Given this list of marker genes CRTC2, PRXL2B, EHMT2, KANSL3 (NCBI Gene Id 55683), IRF9 (interferon regulatory factor 9), GGACT, ARPC3, MYO1G, PLCD1, FAS, NUP210, MSRB1, TMEM107, TRANK1, ABHD14B, MARF1, SPSB2, DNTTIP1, ETFRF1, ZNRF2, CLEC2B, UBAC2, SEL1L3, MAU2 (NCBI Gene Id 23383), ZNF37BP (NCBI Gene Id 7588), EBP, PRKD2, MYBL1, YAF2, TXNDC12, LETMD1, SELENOW, MGAT1, ABHD3, TMED10, DFFB, PI4KB, NAA60, LRRC37A4P, CRYZL1, PHTF1, SPG7, GTF3A, PASK, MED20, ZNF512B, RCN2 (NCBI Gene Id 5955), TTC28-AS1, RNF34, KAT7, THAP8, PCBP1, ZNF780A, CASP8, AKT2, OSGEPL1, CAPNS1, LPGAT1, C2orf74-AS1, IKBKB, PINK1, DERA, TBCC, CARD19, AK3, EFCAB14, MOV10, SLTM, GTF3C2, GLE1, PPP2R5D, TCFL5, TRAM1, PCGF3, VPS41, UVSSA, APOLD1, ABHD15, AHI1-DT, PCBP1-AS1, ZDHHC13, TPM4, SH3BGRL3, SH3BP5-AS1, ERG28 (ergosterol biosynthesis 28 homolog), DIAPH1, RAB2B, RALA, MARCHF2 (NCBI Gene Id 51257), SPIDR, C8orf44, PLOD3, R3HCC1L, DND1, ZNF337, KLHL22, RASAL3, KPNA5 (karyopherin subunit alpha 5), MED22, LCP2, CDK5RAP2, SMC2, SPIN4, HADH, MIA3, SHC1, FBXL14, TMEM38A, PTOV1, TMX3, IPP, SRPK2, NCALD, CAMK1D (NCBI Gene Id 57118), VPS51, NBEAL2, ZYG11B, GANAB, MAGED1, DNASE1L1, CDC14A, SCPEP1, CCDC92, SMYD2, DHRS4-AS1, HNRNPH2, ANKRD49, SLF1, ATRN, NSUN5P2, VPS35L (NCBI Gene Id 57020), IRAG2, TASOR, ATP23, MFNG (MFNG O-fucosylpeptide 3-beta-N-acetylglucosaminyltransferase), DCP1B, RBL1, ZNF407-AS1, RANGRF, CHM, COX15, ATP6V1G1, SAC3D1, TRIM11, CSK, CISD2, TMEM181, ILRUN, TXN2, PARP10, RAD9A, HNRNPU, GOPC, CDRT4, SIGIRR, ZBTB44, CREBBP, MAPKBP1, TPR, CD99L2, EPC2, ERLIN2, CHST12, RAB3GAP2, IGSF8, POLG2, SAMD1, CKMT2-AS1, PPP1R35, ABRAXAS1, HDDC3, NOL4L, MAGED2, NPAT (nuclear protein, coactivator of histone transcription), FXYD5 (NCBI Gene Id 53827), ANTXR2, TRAPPC12, TSC1, HIRIP3, NAA16, EPG5, ACAT2, GSR, PKP4, PML, ENTPD6, VPS4B, ACOT13, PTPN4 (NCBI Gene Id 5775), PHF20L1, WSB1, HERC5, RBM6, ALG10B, SORL1, NDE1, here is a description of the gene set: Genes down-regulated in CD8 T cells: stem cell memory versus central memory. studied in species Homo sapiens An early-differentiated CD8+ memory T cell subset with stem cell-like properties (TSCM) can be identified within the naïve-like T cell population by the expression of CD95/Fas. Based on experiments including exon- and gene-level expression analysis, we provide evidence that this subset of antigen-specific cells represents an early precursor of conventional central (TCM) and effector (TEM) memory CD8+ T cells with enhanced self-renewal capacity and proliferative potential. We identified genes differentially expressed between major T cell subsets defined along with memory T cell commitment. Based on the analysis of these genes, CD95+ naïve T cells (TSCM) cluster closer to the CD8+ T memory compartment than to classical (CD95-) naïve T (TN) cells, and display an intermittent phenotype between classical TN and TCM cells in terms of all major T cell differentiation markers analyzed. Human Gene Set: GSE23321_CD8_STEM_CELL_MEMORY_VS_CENTRAL_MEMORY_CD8_TCELL_DN from publication Gattinoni L, Lugli E, Ji Y, Pos Z, Paulos CM, Quigley MF, Almeida JR, Gostick E, Yu Z, Carpenito C, Wang E, Douek DC, Price DA, June CH, Marincola FM, Roederer M, Restifo NP (PMID 21926977)